The following is a description of a gene set: Human Gene Set: HP_ABNORMAL_TRACHEOBRONCHIAL_MORPHOLOGY species: Homo sapiens Abnormal tracheobronchial morphology, and this is the list of marker genes: CYBB, MAGT1, TRIM2, LRBA (NCBI Gene Id 987), RFX5, SPI1, ARHGEF1, DNAAF2, FANCE, PTEN, CCDC40, SLC26A4, DNAAF5, SLC12A2, STN1, AFF4, CXCR4, HOXD13, CCNO, BACH2, RAI1, ERCC4, CYBA, SLF2, STK36, OTX2, KRAS, SLC6A14, KIF7, RFC2, MALT1, CFAP221, CTLA4, DOCK11 (NCBI Gene Id 139818), PRKN, CEP295, ATP11A, CASP8, USP26, ODAD1, PAICS, IRF8, FNIP1, DNAI1, DNAAF6, EMILIN1, KEAP1, TNFRSF13C (TNF receptor superfamily member 13C), ERBB2, RFX7, WRAP53, DNAH5, GTF2IRD1, BTNL2, KMT2C, HK1, CEACAM3, EBP, IGHG2 (immunoglobulin heavy constant gamma 2 (G2m marker)), DDR2, SCNN1B, ZMYND10, UNC119, KRT14, CCDC39, DNAH1, STAT3, LTBP4, SOX9, SCNN1G (sodium channel epithelial 1 subunit gamma), POLR1C, WBP11, BUB1, FCHO1, MS4A1, HRAS, DNAAF4, CHD6, HFE, FREM2, FANCI, B3GALT6, MUC5B, RPL5, MYH11, KIF22, NCF4, TPP2, IDS, HYLS1, CD79A, NOTCH3, ARL2BP, POLA1, C1QB, UBA2, FANCL, BTK, IGKC, RAC1, PARN, FGFR2, STX3 (NCBI Gene Id 6809), SFTPA1, SEMA3E, MAP3K7, GFRA1, ICOS, FGF20, POLD1, ARNT2, NCKAP1L, VPS37D, KRT5, TCOF1, SNRPB, CCDC65, MIF, DICER1, RAP1B, TNFSF12, IRF1, RET, DEAF1, IGLL1, NCF2 (neutrophil cytosolic factor 2), CEACAM6, RMRP, EMC1, NFKB2, OFD1, CFTR, SPEF2, DNAL1, FANCM, SYK, CARMIL2, SOX3, LRRC56, DNAH11, LTBP3, MCIDAS, ODAD2, RIN2, DNAJB13, FANCC, HYDIN, PALB2, KCNJ10, NPM1, SETD2, METTL27, TRRAP, NOP10, CYP2A6, FRAS1, TTC12, MYRF, STX1A, FBLN5, TONSL, CD81, DNAH9, DSP, FOXJ1, GNPTAB, CLIP2, POLE, CD8A, AGR2, SMARCA2, COL4A6, ELN (NCBI Gene Id 2006), UBE2T, LRRC8A, CR2, RSPH4A, IL21R, NDUFA6, PDGFRB, ATM, USP9X, PIK3CA, COL2A1, POR, TERC, PPP2R1B, FAT4 (NCBI Gene Id 79633), RAC2, LIMK1, CFAP300, PGM3, SPAG1, BLM (NCBI Gene Id 641), RSPH9, DNMT3B, WNT3, MID1, SMAD4 (SMAD family member 4), CARD10, NME8, SLX4, ADAMTSL2, CTC1, IL17RA, B2M, IGHM, MYCN, BRIP1, TGFB1, CYBC1, NME5, SEC61A1, BRCA1, MPEG1, FANCA, TAP2, TYMS, GMNN, MAD2L2, RAD51C, ARSL, DDRGK1 (NCBI Gene Id 65992), GSTM3, FOXF1, IFT56 (NCBI Gene Id 79989), KANSL1, ALDH18A1, BRAF, MGP, SLC41A1, SLC34A2, AMER1, SOX2, NHP2, ZIC3, DNAAF11, SLC11A1, GAS8, TAP1, XRCC2, HDAC4, CHD7, EIF4H, IL6ST, CLCA4, PROKR2, FLII, NCF1, CARD11, ORC6, TP73 (NCBI Gene Id 7161), ICOSLG, NEK10, ODAD3, IL2RG, BRWD1, RAB3GAP2, BRCA2, TMEM270, ITGA8, SFTPA2, FKBP6, IL10RB, TET2, FCGR2A, LBR, CD19, GAS2L2, SLC29A3, CD79B, ERCC6, PIK3R1, DKC1, PAX3, SCUBE3, RASGRP1, FBN2, TINF2, EXTL3, DNAI2, GTF2I, ODAD4, TBL2, FANCF, FLNB, SFTPC, KAT6A, EHMT1, STAT1, LAT, FANCB, ESAM, SLC9A3, TAFAZZIN, SLC22A18, ERF (ETS2 repressor factor), NBN, USB1, TNFRSF13B, KCNN4 (NCBI Gene Id 3783), FOXI1, IRF2BP2, FAM13A, TBX4, POLR1B, DCHS1, AHDC1, RNU4-2, EDNRA, COL4A5, IRF9, WNT7A, PIK3CD, POLG, LMBRD1, GREB1L, GTF2IRD2, TCF3, TNFRSF9, NFKB1, RTEL1, MAP3K8, HMOX1, IDUA, RSPH1, DOCK8, FANCD2, HLA-DPB1, BMPER, SLC39A7, SALL1, PAK2, RPGR, GCLC, RIPK1, BAZ1B, POLR1A, DNAJC30, CCDC103, DHCR7, RSPH3, BLNK, SASH3, POLR1D, DIAPH1, SLC26A2, SERPINA1, HESX1, SCAF4, HLA-DRB1, ABCA3, STK4, RFWD3, CFAP74, EGFR, FASLG, FANCG, BUD23, DPP9, RAD51, DNAAF3, RALGAPA1, ZEB2, CFAP298, PRRX1, DCTN4, WNT9B, WDR26, SLC26A9, GRIP1, WDR1, ORC4, DRC1, RSPO2, PI4KA, GLMN, DNAAF1, FGFR1 (NCBI Gene Id 84151), POLD3, IQSEC2, TERT, PCNT, ZNF699, SCNN1A, ZNF341